Given this list of marker genes CD33, SMS, IRAK3, CHMP2B, PHF10 (PHD finger protein 10), CNN2, RAD23B, CREB5, ENO1, MARCKS (myristoylated alanine rich protein kinase C substrate), PICALM, CLEC10A, CLEC7A, ICAM3, NDRG2, FCGR2A, IL1RN, EVL, ID2B, IQGAP1, PILRA, PAK1, VEGFA, TKT, ANXA2P2, TIPARP, PLEKHO1, RAB7A, ATG3, HLA-DRB6, CIITA, CSTA, RAB31 (NCBI Gene Id 11031), CREG1, APOL3, SLC2A3, JUNB, PTGS1, DPYD, PLAAT4, APAF1, RHOG, LMNA, TNFAIP2, C11orf21, PPT1 (NCBI Gene Id 5538), IPCEF1, SLC25A24, ZFP36L1, PID1, STOM, COL9A2, PTP4A2, PPIF, SLCO3A1, GSTP1, ID2, GMFG, APOBR, C2CD2, PADI2, IFITM2, FGL2, PLBD1 (phospholipase B domain containing 1), NOD2, ALDH3A2, COTL1, SH3BP2, IL6R, TUBA1A, LGALS9, ITPK1 (inositol-tetrakisphosphate 1-kinase), BLVRB, PTPN12, VDAC1, CD1C (NCBI Gene Id 911), EMP3, ARRB1, BCL6, CFP, SQOR, LAT2, CD226, LGALS2, ITGB2, OAS3 (NCBI Gene Id 4940), P2RY13, CSTB, YBX1, SERPINB6, SGK1, RBPJ, CST3, VDR, RNH1, RHOB, ARHGDIB, PSTPIP2, PDLIM1, TMSB10, S100A4, FBXL5, ANXA5 (annexin A5), GRK3, C1orf54, LST1, HIF1A, IFITM3, SPI1, ANXA2, S100A10, KLF11, TRIB1, YWHAH, STX11, SERPINB1 (NCBI Gene Id 1992), PTGER4, GBP2, CUL1, HK2, MAGEF1, RNASE2, MEGF9, CD1D, CD1A, PLXNC1, AIF1, OXA1L, CD86, BCL2, ENTPD1, NCF2, LY86, CEBPD, SEC11A, SPG21, SERINC5, RTN1, FGR, BLOC1S1, EFHD2, MNDA, NDST1, DIAPH1, HLA-DQB1 (NCBI Gene Id 7924), BCL2A1, BASP1, NAIP, IFI30, GBP1, ITGAX, SCO2, RCBTB2, NAMPT, XAF1, FCGR2C, TMBIM1, AOAH, RIN3, ATP2B1, PKM, CD93, GAS7, LGALS1 (galectin 1), PSTPIP1, ASAP1, CASP1, LILRA1, MSN, PTGS2, CYFIP1, PPA1, PTPRC, ANXA1, ITGAM, FCN1, HLA-DRA, CD1E, LY75, HCK (HCK proto-oncogene, Src family tyrosine kinase), AP1B1, ADAM8, LGALS3, CKLF, TBL1X, LMO2, AHR, CTSH, GAPDH, TIMP1, S100A9, ALOX5, IGFBP7 (insulin like growth factor binding protein 7), IL13RA1, BLVRA, LIMD2, CLIC2, RGS10, YBX3, RAB32, here is a description of the gene set: studied in species Homo sapiens Systems vaccinology has emerged as an interdisciplinary field that combines systems wide measurements and network and predictive modeling applied to vaccinology. Here we used the systems vaccinology approach to study the molecular mechanisms underlying th Human Gene Set: GSE29618_PDC_VS_MDC_DN from publication Nakaya HI, Wrammert J, Lee EK, Racioppi L, Marie-Kunze S, Haining WN, Means AR, Kasturi SP, Khan N, Li GM, McCausland M, Kanchan V, Kokko KE, Li S, Elbein R, Mehta AK, Aderem A, Subbarao K, Ahmed R, Pulendran B (PMID 21743478) Genes down-regulated in comparison of plasmacytoid dendritic cells (DC) versus myeloid DCs.